Given this list of marker genes Tspo, Creb1, Mt1, Glra1, P2rx4, Mt4, Grin2a, Mt3, Mtf1 (metal response element binding transcription factor 1), Glra2, Glra3, Mt2, Zfp616, Zfp658, Kcnk3, Gabrg2, Zfp735, Hvcn1, Gabrb3, Gpr39, here is a description of the gene set: species: Mus musculus Mouse Gene Set: GOBP_CELLULAR_RESPONSE_TO_ZINC_ION Any process that results in a change in state or activity of a cell (in terms of movement, secretion, enzyme production, gene expression, etc.) as a result of a zinc ion stimulus.